The following is a description of a gene set: part of: Signaling by SCF-KIT studied in species Mus musculus electronically inferred by orthology from the curated human pathway This event has been computationally inferred from an event that has been demonstrated in another species.<p>The inference is based on the homology mapping from PANTHER. Briefly, reactions for which all involved PhysicalEntities (in input, output and catalyst) have a mapped orthologue/paralogue (for complexes at least 75% of components must have a mapping) are inferred to the other species. Reactome Pathway: Regulation of KIT signaling, and this is the list of marker genes: Yes1, Sh2b3, Prkca, Lck, Cbl, Grb2, Kitl, Ptpn6, Fyn, Kit